Given this list of marker genes Wls, Porcn, Ptpn23, Tmem132a, Vps35, Oprm1, here is a description of the gene set: species: Mus musculus Mouse Gene Set: GOBP_WNT_PROTEIN_SECRETION The controlled release of a Wnt protein from a cell.